The following is a description of a gene set: Human Gene Set: HP_LONG_HALLUX Increased length of the big toe. studied in species Homo sapiens Long hallux, and this is the list of marker genes: NPR2, DPM1, POLR3GL, KAT6B, NPR3 (natriuretic peptide receptor 3), KCNN3, KMT2A (lysine methyltransferase 2A), FIBP, NKX3-2, ZNF668, FAM20C, KCNH1, TRAF7, GNAI1, GNE (NCBI Gene Id 81868), SMS, ZEB2 (zinc finger E-box binding homeobox 2), PTH1R, SCARF2 (scavenger receptor class F member 2), SOX5, PRKAR1A, FLI1